The following is a description of a gene set: Genes up-regulated in wildtype bone marrow-derived macrophages: control versus treated with IL4. from publication Szanto A, Balint BL, Nagy ZS, Barta E, Dezso B, Pap A, Szeles L, Poliska S, Oros M, Evans RM, Barak Y, Schwabe J, Nagy L (PMID 21093321) C57Bl/6 wild-type and STAT6 KO mice were used to study PPARg and IL-4 signaling. Bone marrow of 3 mice per group was isolated and differentiated to macrophages with M-CSF (20 ng/ml). 20 ng/ml IL-4 was used to induce alternative macrophage activation and 1 uM Rosiglitazone (RSG) was used to activate PPARg. From each mouse 4 samples were generated: 1. M-CSF, 2. M-CSF+RSG, 3. IL-4 and 4. IL-4+RSG. All compounds were added throughout the whole differentiation process, and frech media was added every other day. Control cells were treated with vehicle (DMSO:ethanol). After 10 days, RNA was isolated and gene expression profiles were analyzed using Mouse Genome 430 2.0 microarrays from Affymetrix. studied in species Homo sapiens Human Gene Set: GSE25088_CTRL_VS_IL4_STIM_MACROPHAGE_UP, and this is the list of marker genes: DAPK1, GUCY1B1, GPSM3, SOCS2, ADGRL2, ENPEP, A2M-AS1, SV2A, PTP4A3, ABI2, RBM41, TAMALIN, PIP5K1C, SSBP3-AS1, AMOTL1, EPCAM, OTULINL, MED13L, TNFRSF10A, DLEU2, CD93, RAB25, CLINT1, RTKN, ZNF667-AS1, TWIST1, TBC1D22B, LINC03104, NICOL1, PRKD1, TRIO (trio Rho guanine nucleotide exchange factor), BRWD3, PHKB, SUOX, HVCN1, CD8B, DACT1, STARD8, LYN, GPIHBP1, ZNF3, DPYSL2, GNAS, ZNF285, SEMA4C, DLG5, VANGL1, TIA1, DENND4C, CHD1, ATXN1, ARL11, SEC14L1, ASPM, EEIG2, PDLIM1, GLUL, INTS3, LEMD3, LRRC1, GADD45B, AR, CCDC50, SUMO4, LAIR2, TARP, FOXN3, ZC3H12C, KLHL36, NREP, BCL6B, ZNF234, LIMS2, MGLL, B3GNT2, ILK, UBE2E1, CHN2, SWAP70, ZDHHC14, FBRSL1, IQGAP3, KDM5B, LINC00482, ZNF883, ARID2, RAB37, SYPL1, SNN, LY86, SMC4, LINC00877, IRX5, SMAD5, CD33, HIPK2, KDM5A, PARVG, LPAR5, MAP3K20, KLHL6, ADH4, CYTH4, CREB1, MLLT3 (MLLT3 super elongation complex subunit), ASIC1, PAWR, OLAH (NCBI Gene Id 55301), BPTF, SEPTIN9, KANK3, GCNT2, SPIN1, SLCO4C1, RALGDS, DGKH, CISH, CEP85L, IL16, DNMBP, UGGT2, LMCD1, C1orf21, ZNF654 (NCBI Gene Id 84158), CPE, SP3, AEBP1, ARHGEF3, CAT, AHRR, ZNF711, RXRA, CDCP1, IGF2BP3 (NCBI Gene Id 10643), BEND4, LRRC2, AJUBA, TOX, MSL1, IKZF4, PDE6G, MIR924HG, USP33, DSG2, BASP1, TCF4, PDE7B, CALML4, ITPK1-AS1, SLC35F3, TENM2, FN1, IL6ST-DT, SENP7 (NCBI Gene Id 57337), IGFBP2, OVOL1, PLCG1 (phospholipase C gamma 1), SGK1, PCDH9, TCEA3, ETS2, IFNGR2, BTBD3, IKZF2, CBX2, GNB4, CCNG2, ARHGAP32, ITGA5, C3orf18, FAM13A-AS1, TMC8, HDAC9, COL18A1, SCAF11, NOG, CBX4, CRISPLD1, NRIP1, STAC (NCBI Gene Id 6769), SOX4, ZER1 (zyg-11 related cell cycle regulator), EFCAB14, MAU2, MARCKS, ADA, CD96, RIN3, SLCO3A1, HEMK1 (HemK methyltransferase family member 1), CXXC5, ALDH7A1 (aldehyde dehydrogenase 7 family member A1), NFE2L2, PTPN12, FADS1